Given this list of marker genes MPP2, CENPI, TLK2, RENBP, HMGA2, NEFL, PRKCG, RING1, ABCC1, AANAT, VPS72, BCAT2, CSN3, MAPK3, GSTZ1, ZNF76, PLK1, SMARCD1, KRT32, TAF1, DRG2, DPF2, MADD, PRKAG1 (NCBI Gene Id 5571), TTF1, FEV, HDAC1, EBI3, FCGR2B, ZNF134, PMS2P11, TAF11, PDE6B, TIMM17A, GRM4, PNMT, ZNF8, CCR9, WAS, DHPS, PSG7, LYST, TRIP13, FANCC, DGCR6, GPER1, FUT2, AIP, ODF1, TMEM106A, here is a description of the gene set: Neighborhood of PRKAG1 protein kinase, AMP-activated, gamma 1 non-catalytic subunit in the GCM expression compendium studied in species Homo sapiens Neighborhood of PRKAG1 Human Gene Set: GCM_PRKAG1